The following is a description of a gene set: Murine Cytomegalovirus (MCMV) infection leads to early activation of various immune cells, including B and T lymphocytes, before the actual initiation of antigen-specific adaptive immunity. This activation is partly driven by innate cytokines, including type I interferon (IFN), which are induced early after infection. The objective of this study was to address the role of type I IFN in shaping early/innate B and T cell responses to a primary acute viral infection. In order to decipher the specific impact of IFN-I on cell subsets, we performed a genome-wide expression analysis on WT splenic B and CD8 T lymphocytes isolated from C57BL/6 mixed bone marrow chimera mice. This study complements series GSE39555, which focused on early responses of NK cells and of the two subsets of conventional dendritic cells. Human Gene Set: GSE45365_HEALTHY_VS_MCMV_INFECTION_BCELL_IFNAR_KO_DN Genes down-regulated during primary acute viral infection: B lymphocytes versus CD8 T cells. species: Homo sapiens, and this is the list of marker genes: MYLK, LPP, KAT2B, HOTAIR, CCP110, KLHDC4, GINS2, COX4I1, DHTKD1 (NCBI Gene Id 79141), IRF8, NDFIP2, ZNF354C, ABHD6, PTGR1, ENPP1, METTL26, SIAH1, CBS, SH3BGR, SOX7, CEP15, PCOLCE2, GAN, GK, PLOD2, EXOG, SERPINI1, UFSP1, MAGEH1, ST6GALNAC3, WIF1, REEP1, TMTC4, FAM216A, LINC00665, SLC24A1, MICOS10, UBE2I, B3GALNT1, ADCK2, THAP12, C1GALT1C1L, N4BP2, RNF13, FMN2, SENP6, PAM, CENPN, UQCC4, LINC00667, TIMMDC1, CNN3-DT, PIGV, MYEF2, ZC3H18, ITFG1, SESN1, ZNF334, RMI2, CTH, BTC, RGCC, SPON1, ST6GAL1 (ST6 beta-galactoside alpha-2,6-sialyltransferase 1), KRCC1, PDCD10, SELENOF, CSPG5, CENPQ, IQSEC1, CMTM4, NIP7, PUDP, LMBRD1, ARL2BP, PDGFD, RAB40B, ELOVL2, PKP2, CASK, RILPL2, FAM201A, KDSR, APRT, DCAKD, FAS, PRRG1, NUBP1, ZKSCAN2, FAM210B (NCBI Gene Id 81895), PPP1R2, STS, ZNF137P, RMC1, ANXA4, ENOPH1, TRIB3, ASPH, MYBPC1, NAE1, GRHL1, BBS2, ZSCAN5A, PRKAR2B, NINJ2-AS1, RAB25, TRAPPC2L, ELOVL7, GFOD1, C16orf46, HPRT1 (hypoxanthine phosphoribosyltransferase 1), PIGX, TBC1D16, CLDN1, LRRCC1, ALG6, TMEM14C (NCBI Gene Id 51522), XK, PPM1D, EMC8, ZNF43, ANKRD26 (NCBI Gene Id 22852), CHCHD4, SNX4, MPHOSPH6, SHCBP1, LPGAT1, AK9, ZNF232, RAB40C, CAV1, FTO, DDX28, DENND6A, MEAK7, MPG, SFRP1, C16orf87, WLS, LACTB2, ZMYM6, SULT1A1, TMEM45A (transmembrane protein 45A), ZNF468, DPYSL2, LHFPL4, KCNC1, ZNF23, TNFRSF10D, PLCG2, RBBP7, RPUSD3, RC3H2, GPR180, ELAC1, SELENOP, COQ9, VPS37A, ATRAID, CYB5B, VKORC1, OAT, GADD45A, CHST11, KCNQ5, TSEN2 (NCBI Gene Id 80756), SPATA17, BANP, TSC22D3, CDH3, ZNF600, TCTN1, TCF25, USP7, C2orf74, PIGP, LAMP3, DBR1, IRF6, USP33 (ubiquitin specific peptidase 33), KLHL36, ZNF32, ZNF700, HSD17B6, POLR3K, MTFR1L, ZFP90, PABPC4L, TNMD, SLC2A10, FBXO9, IKBIP (IKBKB interacting protein), GPM6A, SMARCE1, UTP4, ZFPM1